Given this list of marker genes Ap1g1, Bloc1s3, Drd2, Myo7a, Cdh3, Rab11a, Myo5a, Tyrp1, Ap1s1, Ednrb, Kitl, Bloc1s6, Ankrd27, Oca2, Mlph, Adamts20, Pomc, Rab38, Dtnbp1, Bloc1s1, Mitf, Hps5, Map2k1, Ap3s2, Recql4, Atp7a, Ap3b1, a, Rab32, Ap3s1, Mc1r, Lyst, Ap1b1, Nf1, Grk3, Gnat1, Vhl, Kit, Shroom3, Pax3, Krtap21-1, Mfsd12, Slc45a2, Gli3, Hps3, Myc, Gnaq (NCBI Gene Id 71788), Fig4, Zeb2, Bcl2l11, Zic2, Rack1, Snai2, Bace2, Sparc, Cd63, Ugt1a1, Krt76, Hps6, Edn3, Ap3m1, Arcn1, Spns2, Atp6ap2, Ap1s3, Adamtsl4, Lrmda, Hps1, Rab29, Rab27a, Vps33a, Bax, Mreg, Adamts9, Kif13a, Vps33b, Bcl2, Szt2, Or51e2, Sox10 (NCBI Gene Id 20665), Ap1s2, En1, Cited1, Atrn, Hps4, Rab17, Abcb6, Rab1a, Pmel, Gna11, Ap1m1, Bloc1s5, Ihh, Pikfyve, Tpcn2 (two pore segment channel 2), Dctn2, Dock7 (dedicator of cytokinesis 7), Mysm1, Rab11b, Snapin, Ednra, Tbx2, Dctn1, Apoe, Gnat2, Eda, Bloc1s2, Gpr143, Vangl1, Tyr, Bloc1s4, Mef2c, Enpp1, Dct, Edar, Shroom2, Sod2, Ap3d1, here is a description of the gene set: species: Mus musculus Mouse Gene Set: GOBP_PIGMENTATION The accumulation of pigment in an organism, tissue or cell, either by increased deposition or by increased number of cells.